Given this list of marker genes TACC1, CD74, MMP14, CD48, PF4, UBD, CTSK, TNFAIP3, ACTR2, FGL2, RNF216, CLDN10, SLF2, PLD1, FAM13A, SNAI2, OSBPL1A (NCBI Gene Id 55097, oxysterol binding protein like 1A), MPZL1, CPXM1, DSC3, RTL8C, HDAC2, KMT2A, SLC8A1, MSH2, NGF, CLDN7, GPX2, PCNA, GTF2B, CD3D, ANXA1, LAMB1, CAP1, HSPA1B, GOLGB1, RASGRP1, LGALS4, PSMB9, PPP1CB, RGCC, FRZB, SH3YL1, UBE2A, GABRE, STAT1, ITGBL1, SLC12A2, TCF4, H2BC7, ATRX, TES, NKG7, CDH13, AKAP13, LUM (NCBI Gene Id 4060), CDH1, P3H4, CYP3A7, POU2F2, RALY, AOAH, here is a description of the gene set: studied in species Homo sapiens BACKGROUND: It is a challenge to identify patients who, after undergoing potentially curative treatment for hepatocellular carcinoma, are at greatest risk for recurrence. Such high-risk patients could receive novel interventional measures. An obstacle to the development of genome-based predictors of outcome in patients with hepatocellular carcinoma has been the lack of a means to carry out genomewide expression profiling of fixed, as opposed to frozen, tissue. METHODS: We aimed to demonstrate the feasibility of gene-expression profiling of more than 6000 human genes in formalin-fixed, paraffin-embedded tissues. We applied the method to tissues from 307 patients with hepatocellular carcinoma, from four series of patients, to discover and validate a gene-expression signature associated with survival. RESULTS: The expression-profiling method for formalin-fixed, paraffin-embedded tissue was highly effective: samples from 90% of the patients yielded data of high quality, including samples that had been archived for more than 24 years. Gene-expression profiles of tumor tissue failed to yield a significant association with survival. In contrast, profiles of the surrounding nontumoral liver tissue were highly correlated with survival in a training set of tissue samples from 82 Japanese patients, and the signature was validated in tissues from an independent group of 225 patients from the United States and Europe (P=0.04). CONCLUSIONS: We have demonstrated the feasibility of genomewide expression profiling of formalin-fixed, paraffin-embedded tissues and have shown that a reproducible gene-expression signature correlated with survival is present in liver tissue adjacent to the tumor in patients with hepatocellular carcinoma. Human Gene Set: HOSHIDA_LIVER_CANCER_LATE_RECURRENCE_UP from publication Hoshida Y, Villanueva A, Kobayashi M, Peix J, Chiang DY, Camargo A, Gupta S, Moore J, Wrobel MJ, Lerner J, Reich M, Chan JA, Glickman JN, Ikeda K, Hashimoto M, Watanabe G, Daidone MG, Roayaie S, Schwartz M, Thung S, Salvesen HB, Gabriel S, Mazzaferro V, Bruix J, Friedman SL, Kumada H, Llovet JM, Golub TR (PMID 18923165) Genes whose expression correlated with higher risk of late recurrence of hepatocellular carcinoma (HCC).